Given this list of marker genes KLF10, AMFR, HASPIN (histone H3 associated protein kinase), NOLC1, CYP2B7P, DSCC1, CDC45, TMA16, ORC1, FAM216A, BRIP1, CAP2, MCM2, BLM, HSPD1, MOCOS, UBE2T, here is a description of the gene set: from publication Li Z, Li T, Yates ME, Wu Y, Ferber A, Chen L, Brown DD, Carroll JS, Sikora MJ, Tseng GC, Oesterreich S, Lee AV (PMID 37272757) High confident estrogen up-regulated genes in non-MCF7/T47D breast cancer cell lines merged from 44 NGS datasets-based comparisons (10% topmost up-regulated genes and consistent in at least 40% comparisons). Human Gene Set: LI_ESTROGENE_NON_MCF7_T47D_E2_RESPONSE_UP As one of the most successful cancer therapeutic targets, estrogen receptor-alpha (ER/ESR1) has been extensively studied over the past few decades. Sequencing technological advances have enabled genome-wide analysis of ER action. However, comparison of individual studies is limited by different experimental designs, and few meta-analyses are available. Here, by ingesting large amount of E2-related transcriptomic data sets in breast cancer cell lines, we identified gene expression changes across 66 RNA-seq and 80 microarray experiments based upon the E2-induced fold change in gene expression. MCF7 and T47D cell lines have been used extensively as ER+ breast cancer models. However, extrapolation of this data to breast cancer is complicated by the known heterogeneity of breast cancer and potential biases arising from cell line-specific results. Importantly, while EstroGene contains transcriptomic data from 19 different breast cancer cell lines, data from MCF7 and T47D account for ~50% and ~20%, respectively, of all experiments. To characterize and describe contextual cell-line specific responses, we identified the top 10th percentile of upregulated and downregulated genes in an individual study and consistent among 50% of comparisons within MCF7 or T47D experiments. For non-MCF7/T47D experiments we lowered the threshold to 40% across studies due to the larger heterogeneity in this subset. Intersection of the three subsets yielded 89 and 96 uniquely regulated genes in MCF7 and T47D, we also identified genes that were not regulated in MCF7 and T47D but showed E2-induction in some other cell lines. species: Homo sapiens